Given this list of marker genes EXT2, ATRX, BCKDK, MAP1B, PDCD6IP, CTCF, here is a description of the gene set: studied in species Homo sapiens Underdevelopment of the philtrum. Hypoplastic philtrum Human Gene Set: HP_HYPOPLASTIC_PHILTRUM